The following is a description of a gene set: species: Homo sapiens Any process that results in a change in state or activity of an organism (in terms of movement, secretion, enzyme production, gene expression, etc.) as a result of a muramyl dipeptide stimulus. Muramyl dipeptide is derived from peptidoglycan. Human Gene Set: GOBP_RESPONSE_TO_MURAMYL_DIPEPTIDE, and this is the list of marker genes: JAG1, NOTCH1, RIPK2, CARD9, CHMP5, INAVA, RELA, NOD1, NAGK, TNFAIP3, IRF5, NLRP1, PTPN22, ARHGEF2, ERBIN, MAPK14, TRIM41, NOD2, NFKBIA, LDOC1, VIM